Given this list of marker genes TP53BP2, TRIAP1, BCL2L14, PMAIP1, ATM, NDRG1, BBC3, TP53INP1, PIDD1, TP53I3, CRADD, CASP2, TP73, TMEM219, BAX, STEAP3, AIFM2, BNIP3L, TNFRSF10C, CREBBP, PRELID1, CASP1, BCL6, CHM, NLRC4, RABGGTB, CASP10, CASP6, FAS, BIRC5, PERP, TNFRSF10D, PRELID3A, RABGGTA, TNFRSF10B, TP53AIP1, BID, ZNF420, TP53, TNFRSF10A, APAF1, IGFBP3, TP63, PPP1R13B, here is a description of the gene set: species: Homo sapiens part of: Transcriptional Regulation by TP53 The tumor suppressor TP53 (p53) exerts its tumor suppressive role in part by regulating transcription of a number of genes involved in cell death, mainly apoptotic cell death. The majority of apoptotic genes that are transcriptional targets of TP53 promote apoptosis, but there are also several TP53 target genes that inhibit apoptosis, providing cells with an opportunity to attempt to repair the damage and/or recover from stress. <br>Pro-apoptotic transcriptional targets of TP53 involve TRAIL death receptors TNFRSF10A (DR4), TNFRSF10B (DR5), TNFRSF10C (DcR1) and TNFRSF10D (DcR2), as well as the FASL/CD95L death receptor FAS (CD95). TRAIL receptors and FAS induce pro-apoptotic signaling in response to external stimuli via extrinsic apoptosis pathway. IGFBP3 is a transcriptional target of TP53 that may serve as a ligand for a novel death receptor TMEM219.<p>TP53 regulates expression of a number of genes involved in the intrinsic apoptosis pathway, triggered by the cellular stress. Some of TP53 targets, such as BAX, BID, PMAIP1 (NOXA), BBC3 (PUMA) and probably BNIP3L, AIFM2, STEAP3, TRIAP1 and TP53AIP1, regulate the permeability of the mitochondrial membrane and/or cytochrome C release. Other pro-apoptotic genes, either involved in the intrinsic apoptosis pathway, extrinsic apoptosis pathway or pyroptosis (inflammation-related cell death), which are transcriptionally regulated by TP53 are cytosolic caspase activators, such as APAF1, PIDD1, and NLRC4, and caspases themselves, such as CASP1, CASP6 and CASP10.<p>It is uncertain how exactly some of the pro-apoptotic TP53 targets, such as TP53I3 (PIG3), RABGGTA, BCL2L14, BCL6, NDRG1 and PERP contribute to apoptosis.<p>TP53 is stabilized in response to cellular stress by phosphorylation on at least serine residues S15 and S20. Since TP53 stabilization precedes the activation of cell death genes, the TP53 tetramer phosphorylated at S15 and S20 is shown as a regulator of pro-apoptotic/pro-cell death genes. Some pro-apoptotic TP53 target genes, such as TP53AIP1, require additional phosphorylation of TP53 at serine residue S46. Phosphorylation of TP53 at S46 is regulated by another TP53 pro-apoptotic target, TP53INP1. Additional post-translational modifications of TP53 may be involved in transcriptional regulation of genes presented in this pathway and this information will be included as evidence becomes available.<p>Activation of some pro-apoptotic TP53 targets, such as BAX, FAS, BBC3 (PUMA) and TP53I3 (PIG3) requires the presence of the complex of TP53 and an ASPP protein, either PPP1R13B (ASPP1) or TP53BP2 (ASPP2), indicating how the interaction with specific co-factors modulates the cellular response/outcome.<p>TP53 family members TP63 and or TP73 can also activate some of the pro-apoptotic TP53 targets, such as FAS, BAX, BBC3 (PUMA), TP53I3 (PIG3), CASP1 and PERP.<p> <br>For a review of the role of TP53 in apoptosis and pro-apoptotic transcriptional targets of TP53, please refer to Riley et al. 2008, Murray-Zmijewski et al. 2008, Bieging et al. 2014, Kruiswijk et al. 2015. Reactome Pathway: TP53 Regulates Transcription of Cell Death Genes